The following is a description of a gene set: studied in species Mus musculus Mouse Gene Set: GOBP_ACTIN_MYOSIN_FILAMENT_SLIDING The sliding movement of actin thin filaments and myosin thick filaments past each other., and this is the list of marker genes: Tnnc1, Myo9b, Myl6, Tnni3, Mylk2, Actc1, Myh8, Tpm1, Tnnt2, Myh6, Myl6b, Dbn1, Myh7